The following is a description of a gene set: Human Gene Set: MUELLER_METHYLATED_IN_GLIOBLASTOMA studied in species Homo sapiens Glioblastoma, the most aggressive and least treatable form of malignant glioma, is the most common human brain tumor. Although many regions of allelic loss occur in glioblastomas, relatively few tumor suppressor genes have been found mutated at such loci. To address the possibility that epigenetic alterations are an alternative means of glioblastoma gene inactivation, we coupled pharmacological manipulation of methylation with gene profiling to identify potential methylation-regulated, tumor-related genes. Duplicates of three short-term cultured glioblastomas were exposed to 5 microM 5-aza-dC for 96 h followed by cRNA hybridization to an oligonucleotide microarray (Affymetrix U133A). We based candidate gene selection on bioinformatics, reverse transcription-polymerase chain reaction (RT-PCR), bisulfite sequencing, methylation-specific PCR and matrix-assisted laser desorption/ionization time-of-flight mass spectrometry. Two genes identified in this manner, RUNX3 and Testin (TES), were subsequently shown to harbor frequent tumor-specific epigenetic alterations in primary glioblastomas. This overall approach therefore provides a powerful means to identify candidate tumor-suppressor genes for subsequent evaluation and may lead to the identification of genes whose epigenetic dysregulation is integral to glioblastoma tumorigenesis. from publication Mueller W, Nutt CL, Ehrich M, Riemenschneider MJ, von Deimling A, van den Boom D, Louis DN (PMID 16909125) Genes up-regulated in short-term cultured glioblastomas after azacitidine treatment., and this is the list of marker genes: SPINT1, DAZL, KRT19, IER3, LXN, TES, S100P, SPANXA1, GZMM, TKTL1, AREG, KRT17, SERPINF1, SERPIND1, KRT81, CGB3, F11R, NPTX2, MAGEB2, FBXO2, CXCL2, SSX1, COX7A1 (NCBI Gene Id 1346), IL24, LAPTM5, SAP25, CLDN4, MAST3, SPANXB1, SFN, HSD17B6, IFNA21, S100A4, RUNX3, TLR2, KRT4, SSX3, SSX2 (SSX family member 2), MMP13, LCN2, CDA, STAG3, LSR